The following is a description of a gene set: Human Gene Set: GNF2_ITGAL Neighborhood of ITGAL Neighborhood of ITGAL integrin, alpha L (antigen CD11A (p180), lymphocyte function-associated antigen 1; alpha polypeptide) in the GNF2 expression compendium studied in species Homo sapiens, and this is the list of marker genes: BTN3A3, C11orf21, STK10, PLAAT4, ADCY7, MBNL1, GPR65, GZMM (NCBI Gene Id 3004), ARHGEF3 (Rho guanine nucleotide exchange factor 3), TMC6, TRAF3IP3 (TRAF3 interacting protein 3), JAK1, BIN2, RASSF1, ARHGAP45, HLA-F, RAP1B, PTPRC, SIGIRR, STK38, RASGRP1, NPRL2, PTGER2, PTPN4, CYTH1, GIMAP6, SUN2, LCP2, CASP8, CBLB, SIPA1, CTSW, ADGRE5, CD96, KLRB1, SEMA4D, FYN, ABHD17A, SYNRG (synergin gamma), PRKCH, BTN3A2, CD247, ZAP70, KLRK1, BTN3A1, ITGAL, ARL4C, VPS16, CLEC2B, SNRK, PARP8, RIGI, CD7, DUSP2, CYTIP